The following is a description of a gene set: Reactome Pathway: Regulation of endogenous retroelements by the Human Silencing Hub (HUSH) complex part of: Regulation of endogenous retroelements The Human Silencing Hub (HUSH) complex comprises MPHOSPH8 (MPP8), Periphilin (PHPLN1), and TASOR, which appears to act as a scaffold that binds the other subunits. The HUSH complex preferentially represses transcription of young LINE1 retroelements and some HIV integrants.<br>The HUSH complex creates repressive chromatin in two ways. Firstly, HUSH can cause spreading of existing heterochromatin by binding existing trimethylated H3K9 and recruiting SETDB1 to trimethylate H3K9 of adjacent nucleosomes. Secondly, HUSH can initiate heterochromatin by binding nascent transcripts via its PHPLN1 subunit and recruiting SETDB1 to trimethylate lysine-9 of histone H3 (H3K9) at the locus being transcribed.<br>By an uncharacterized mechanism, the HUSH complex targets long intronless cDNAs, such as those produced by retroelements, as well as unusually long exons of normal cellular genes. Introns somehow protect against silencing by HUSH, though actual splicing is not required. In mice, ZNF638 (NP220, Znf638 gene) recruits the HUSH complex to unintegrated murine leukemia virus (MLV) and in human cells ZNF638 (NP220) and HUSH silence recombinant adeno-associated viruses. The potential recruitment of HUSH by ZNF638 to human retroelements is not yet demonstrated. species: Homo sapiens, and this is the list of marker genes: H2AZ2, H2BC13, EHMT1, H2AJ, H2BC21, H3C15, H3C1, H2AX, PPHLN1, ATF7IP, H2BC4, H2BC1, H2BC17, H2AC20, H2BC26, ZCCHC8, H2AC4, H2BC9, MPHOSPH8, H2AC14, TASOR, H2AC7, H2BC12L, H2BC3, MORC2, RBM7, MTREX, EHMT2, H2BC15, H3-3A, H2AB1, H2BC14, H4C1, H2BC12, H2BC11, SETDB1, H2AC18, H2AC6, H2BC5